Given this list of marker genes Acsl1, Acsbg2, Slc27a2, Slc27a1, Acsl5, Acsl4, Acsl3, Slc27a6, Slc27a4, Slc27a3, Acsl6, here is a description of the gene set: Mouse Gene Set: GOMF_ARACHIDONATE_COA_LIGASE_ACTIVITY species: Mus musculus Catalysis of the reaction: arachidonate + ATP + CoA = AMP + arachidonoyl-CoA + diphosphate + H+.